Given this list of marker genes Kbtbd8, Fam83d, Bambi, Msx2, Trip10, Alx1, Ddx17, Qki, Rflnb, Zfp750, Epb41l5, Adam8, Eomes, Spsb3, Dact3, Fermt2, Nolc1, Wnt16, Tgfb2, Dab2, Fbxo11, Smad7, Crb2, Acvr1, Nkx2-1, Glipr2, Hdac2, Lrp6, Sdcbp (NCBI Gene Id 53378), Nog, Jag1, Ezh2, Bcl9l, Hnrnpab (NCBI Gene Id 77086), Hpn, Has2, Fgfr1, Heyl, Akna, Smad2, Phldb2, Snai1, Ldlrad4, Spry1, Tmem100, Spred2, Wnt2, Tbx20, Edn1, Tcf7l2, Pdcd6, Rtn4, Hif1a, Notch4, Grem1, Rgcc, Il1b, Rock1, Foxc1, Ell3, Kdm1a, Col1a1, Ptk2, Vasn, Dag1, Isl1, Smad4, Tbx3, Rian, Foxa1, Gcnt2, Rbpj, Ovol2, Aplf, Ednra, Tgfbr2, Nfatc1, Hey1 (hairy/enhancer-of-split related with YRPW motif 1), Tgfb1i1, Wnt5a, Tgfb1, Lrg1, Epha3, Tgfbr1, Snai2, Mad2l2, Mdk, Vangl2, Fgf8, Gata3, Foxa2, Tsc2 (TSC complex subunit 2), Smad3, Hey2, Fuz, Ppp2ca, Trim28, Zfp703, Pten, Myocd, Gsc, Twist1 (NCBI Gene Id 22160), Sfrp2, Polr1b, Wnt11, Loxl2, Slc39a10, Slc39a6, Bmp7, Bmpr1a, Tgfbr3l, Il6, Vegfa, Sp6 (NCBI Gene Id 83395), Mtor, Trim62, Tgfbr3, Bmp4, Ncam1, Phldb1, Olfm1, Epha4, Mcrip1, Cul7, Lef1, Ctnnb1, Ager, Flna, Dab2ip, Bmp2, Sdhaf2, Emp2, Spry2, Fgfr2, Eng, Ddx5, Axin2, Chrd, Pofut2, Tasor, Clasp2, Kat8, Klhl12, Notch1, Pef1, Mark1, Adam15, Spred3, Clasp1, Tiam1, Efna1, Loxl3, Agt, Msx1, Gsk3b, Hmga2, Tcof1, Wwtr1, Acvrl1, Sox9, Dlg5, Pdpn, Ppp3r1, Pawr, Spred1, Il17rd, Sfrp1, Adipor1, Usf3, Pdcd4, Tgfb3 (NCBI Gene Id 21809), Wnt4 (NCBI Gene Id 22417), Gja1, Rock2, Dsg2, here is a description of the gene set: species: Mus musculus A transition where an epithelial cell loses apical/basolateral polarity, severs intercellular adhesive junctions, degrades basement membrane components and becomes a migratory mesenchymal cell. Mouse Gene Set: GOBP_EPITHELIAL_TO_MESENCHYMAL_TRANSITION